The following is a description of a gene set: Human Gene Set: GOBP_CELL_JUNCTION_ORGANIZATION studied in species Homo sapiens A process that is carried out at the cellular level which results in the assembly, arrangement of constituent parts, or disassembly of a cell junction. A cell junction is a specialized region of connection between two cells or between a cell and the extracellular matrix., and this is the list of marker genes: CSK, DSP, TJP1, GDF2 (NCBI Gene Id 51423), NPAS4, DKK1, LNX1, FLRT2, PLXNB2, APLNR (NCBI Gene Id 187), ITGA3, WDPCP, TSC1, MYADM, CARMIL3, PKP2, GJB1, ITGB1, PIP5K1A, PSEN1 (presenilin 1), PCDHB14, PCDHB13, ADAM10, NRCAM, NRG3, C1QC, PTPRA, SNAI1, CAPRIN2, ABL1 (NCBI Gene Id 25), MIR431, PTEN, SEMA3F, CAV1, KIF5B, CDH22, ELMO1, CLDN6, UBE3B, KIRREL3, ACTG1, NECTIN3, LRRN1, RPS6, MYH10, PPFIA1, C1QL1, PCDHB10, CBLN4, NF1, MYCBP2, PTPRD, VCL, YWHAZ, SLC8A3, GABRG2, CDH2, APBB2, P2RX2, LRRC4B, CHD4, RAP2A, APOD, LRP4 (NCBI Gene Id 4038), DAPK3, FRMPD4, PERP, PPFIA4, SYN1, IL10, ITGA6, IL1RAPL1, DAG1, CNKSR2, VANGL2, CACNG2, NEGR1, PRKCA, GRM6, NGEF, CAST, CX3CL1, NFATC4, CLDN8, CDH6, PTK2B, LGMN (legumain), NTRK2, LHFPL4, DIP2A, TAOK2, GABRA4, NRP1, SEMA4D, SH3GL2, NFIA, LIMCH1, OPHN1, FZD5, HIPK1, VEGFA, FNTA, PTK2, IKBKB, CNTNAP2, CHRDL1, C5AR1, PTPRO, ALS2, SRF, BDNF, EPHA3, GABRA3, AGRN, FBXO45, SDF4, TBX5 (NCBI Gene Id 6910), CSMD2, CDH20, CBLN2, CD2AP, TANC1, OCEL1, CDH1, DRD1, ASIC1, GABRA6, RTN4, SLC30A1, CC2D1A, RAC3, ASIC2, SEZ6, GJB2, ZNF365, CACNA1S, CNTN6, COL4A5, RAPGEF2, DLG5 (discs large MAGUK scaffold protein 5), AGT, GABRA5, CDHR3, ROCK1, DAB2IP, SLC1A1, CLDN12, NTN1, GRID1, C1QB, ACTL8, PLXND1, LAMC1, RHOB, STRN, GAP43, RAB13, LRRTM3, CDH9, IQSEC1, CACNA2D2, CAMK2B, COL16A1, SLITRK5, ANAPC2, CRKL, ROBO2, WDR1, PFN1, PKN2, CHRNB1, MARVELD3, SRGAP2, BMP6, COL17A1, TUBB, ADD2, EFNB2, NPHP1, CDH19, TRPV4, ITGB1BP1, DHX36, PARD3, TLN1 (NCBI Gene Id 7094), ERBB4, BCAN, ZC4H2, NEDD4, NTRK3, HDAC6, DISC1, PHLDB2, SLC6A1, WHRN, EFNA1, GABRA2, MARVELD2, DAAM1, C3, CX3CR1, ZMYND8, DAB1, MEF2C, SNCB, GRHL1, ADGRB3, CNTNAP1, CLDN22, NAE1, POTEF, STRN4, ACE2, LRP8, PEAK1, GIT1, RIMS2, FAM107A, PTPRF, PPFIA3, DST, ELFN1, INSYN1, AFDN, LRFN1, POLDIP2, ZNF703, POTEJ, MECP2, NR1H4, LRFN2, LDB1, LRRC4, SLITRK2, CLDN3, FRRS1L, BCL2, SPARCL1, CLDN18, DLC1, L1CAM, APOE, LARGE1, BHLHA15, PDZD11, PCDHB4, CLASP1, TANC2, CTNNB1, CLDN17, SLC25A46 (solute carrier family 25 member 46), LMX1A, ITGA5, PCDH17, CNTN5, IL10RA, CLDN9, PAFAH1B1, BAIAP2, FRMPD2, LIMS2, TMEM108, INS, ARHGAP39, ITGA2, CNTN2, CACNB4, ABCC8, C1QL3, KIRREL1, SNCG (NCBI Gene Id 6623), SDK1, CDH10, ZDHHC12, CASKIN1, DOCK10, REST, CNTN4, SLITRK4, LRRK2, SRGAP2B, SEMA4C, IL1B, CBLN1, PGRMC1, GPBAR1, NEDD8, EPHA2, DIXDC1 (DIX domain containing 1), CAPZA1, GRID2, SHANK2, MYOT, CPNE6, MAPRE2 (NCBI Gene Id 51683), CHRNA1, EPHA4, NLGN2, AGO2, SDC4, PRNP, CCM2, S1PR2, CLSTN2, SPG11, TNC, ITPKA, LZTS1, PATJ, CDH15 (NCBI Gene Id 1013), MPP7, DVL1, LILRB2, CLDN14, CORO1C, GJC1, ADNP, CDH11, CRK, PRKACA, CLN3, ESAM, DOCK1, RAB39B, AFG3L2, CLDN15, LGI2, CLSTN1, LATS1, PALM, RAC1, TBCD, WASF3, MAP4K4, IL1RAP (interleukin 1 receptor accessory protein), PDCD6IP, GJA10, LIMS1, ARHGAP33, MTMR2, RAPGEF1, POF1B, CHRNB2, NEDD4L, ICAM5, WASL (NCBI Gene Id 8976), CDKL5, AJM1, ERC1, RAB29, PLXNC1, NECTIN1, PRICKLE1, CRMP1, PIK3R1, SLK, CLDN16, NTNG2, THBS1, CACNA2D3, CDC20, GJA5, PIN1, SNAI2, STAU1, SPECC1L, CAMKV, SEMA3E (NCBI Gene Id 9723), GHSR, PIP5K1C, RHOC, PLXNA1, FGF7, COL4A1, MACF1, SLC18A3, PLXNB3, CHRNA7, POU4F1, PCDHB16, CDH3, KCNJ8, KLK8, PCDHB2 (NCBI Gene Id 91503), SIGMAR1, ARMCX5-GPRASP2, PTPRS, DNAJA3, RER1, KDR, STON1, CD177, TRIM47 (NCBI Gene Id 91107), FERMT2, GPR158, CLDN10, NUMBL, DMPK, INSR, ZDHHC17, TGFB2, AMIGO2, CYFIP2, MRTFB, PTPN23 (NCBI Gene Id 96248), CLDN4, LRFN5, ACTB, DUSP22, WNT4, NPTN (neuroplastin), ADGRB1, NOS1AP, CAMK1, PCDH8, RAB8B, VPS35, IL1RAPL2, DSG3, HMCN2, NLGN4Y, ARHGAP12, FCGR2B, SPTBN2, NEFH, CRIPT, GRN, LAMA3, SPTBN4, SPOCK2, HTR4, ZDHHC2, RHOD, MESD, PKP3, CLDN24, CAP1, SPTB, LRIT3 (leucine rich repeat, Ig-like and transmembrane domains 3), NRN1, CSF1R (NCBI Gene Id 8156), SETD5, DSC1, SYNGAP1, CDH5, TJP3, FARP1, ACVRL1, PCDHGC3, DTNBP1, TEK, RAP1A, ARHGAP6, CFL1, MYOC, CTNNA1, ACTN1, PDZRN3, LAMTOR2, PDXP, F2R, CRB3, RHOA, PLEKHA7, RDX, AKT1, SLC39A9, TUBA1A, CUX2, DNER (NCBI Gene Id 92737), CLDN1, SHISA6, WNT7A, FLRT1, LIM2, ITGAM, NRXN1, TRIP6, EXT1, ITGB3, THBS2, UGT8, TENM4, PLXNB1, COLQ, NLGN3, SSH1, CDH24, THY1, MMP14, GRM5, PKHD1, TJP2, TMIGD1, GET1, CCDC39, SLITRK1, AMOT, LAMB2, RIMS1, MARK1, RAB17, RYK, SRGAP2C (NCBI Gene Id 653464), VMP1, CDH4, C1QA, ERC2, INAVA, BCR, CTTNBP2, ADGRL2, ARHGAP22, CTTN, SORT1, SRPX2, FYN, SYNDIG1, PRMT8, CTNNA2, CDH8, CDK5R1, NPHP4, GRIA1, SYN3, CAPRIN1, CBLN3, ARHGEF15, PPP1R9B, GABRA1, STK38, SIPA1L1, CLDN7, SRCIN1, ADD1 (adducin 1), DOCK4, GABRB3 (NCBI Gene Id 2562), HEG1, PARD6B, PLXNA4, FZD9, EFNA5 (ephrin A5), DOK7, CYFIP1, LRRTM2, ILDR1, WASF2, ANK3, LRFN4, NF2, HDAC7, PDLIM5 (PDZ and LIM domain 5), MYO9A, TNR, SORBS1, RAB3A, RELN, PAK3, PTK7, SLC9A1, SEZ6L, PFN2, FKRP, LRRC4C (leucine rich repeat containing 4C), TGFBR1, ABI3, PAK2, CLASP2, TLR2, HIP1R, RAP1B, RTN4R, NEFL (NCBI Gene Id 4747), HRG, DLGAP4, GPM6B, OXT, EEF2K, NLGN4X, NCKIPSD, IQSEC2, NRP2, PCDHGC5, PPFIA2, GPRASP3, SIX1, GJA4, GRIN2B, MIR142, F11R, SLITRK6, CDC42, ACTBL2, CAP2, PCLO, LZTS3, PECAM1, ERBB2 (NCBI Gene Id 2064), GRHL2, GPC4, VSIG10, MTSS1, GJA1, LINGO2, SH3BP1, GHRL (ghrelin and obestatin prepropeptide), MAPT, GJD3, CD9, NTRK1, DUSP3, NLGN1, NEURL1, FLRT3 (fibronectin leucine rich transmembrane protein 3), DBNL, GNPAT, GABRG3, LRTM2 (leucine rich repeats and transmembrane domains 2), CDH12, ADGRL3, MICALL2, SNCA, SLITRK3, FGFR1, SEMA4A (semaphorin 4A), EIF4G1, PKP4, PLXNA2, TESK2, PRKCH, TREM2, CDH17 (NCBI Gene Id 1015), GDNF (NCBI Gene Id 2668), NEUROD2, FSCN1, CDH7, ACHE, OGT, NRXN2, PCDHGC4, FGF22, DSG2, SNX27, ARHGEF9, APPL1, NTNG1, HAPLN4, FLOT1, PTPRJ, PLXNA3 (NCBI Gene Id 8276), PPM1F, EPB41L3, AMIGO1, ELFN2, SVEP1, FLCN, NPTX1, FER, ROCK2, PARD6A (par-6 family cell polarity regulator alpha), ARC, PTPN13, WASF1, GPM6A, CLDN34, ST8SIA2, DLGAP3, PLS3, CACNB2, EPB41L5, GSG1L, EGLN1, GNA13, BSN, KIFC3, FN1, CHCHD10, MIR105-1, NPHS1, GABRB2 (gamma-aminobutyric acid type A receptor subunit beta2), LIN7B, FBF1, LSR, DSG1, RAPSN, ARHGEF7, DNM3, ADGRF1, KIF2C, PRTN3, THSD1, PTPRK, CLDN19, DLG4, VCP, AJUBA, EPHB1, OCLN, IGSF11, WNT7B (NCBI Gene Id 7477), KY, SDK2, ACTN2 (NCBI Gene Id 88), ACTN3, LIN7C, AGAP1, CHMP2B, RCC2, WNT11, ABHD17B, ZDHHC8, TPBG, MPDZ, UBE2M, CORO2B, XIRP2, PICK1, ENAH, PCDHB3, PKP1, MAPK14, GLRB (glycine receptor beta), EZR, ZDHHC15, GREM1, SARM1, CDH18, EPHB3, EPHA7, PLPPR4, RPS6KA5, PCDHB6, ARL2, MUSK, CAMSAP3, CDH26, FZD1, SPARC, LRFN3, DCTN1, KPRP, FILIP1, LRRTM1, CLSTN3, SRC, CLDN5, PPFIBP2, POTEKP, JUP (NCBI Gene Id 3728), SHISA7, TNF, ABHD17A, MYLK3, ARF4, SIX4, IGF1R, ARHGAP44, CLDN20, TNS1, MYO1C (NCBI Gene Id 4641), APP, SHANK3, DLG1, IGSF9, RHOG, MAP1B, KCNK13, SYBU, GJB6, CDK5, DRP2, ITSN1, KIF1A, RAMP2, FGF13, SENP1, SLC8A2, CLDN11, PCDHB11, DSCAM, DBN1, LRRN3, PLEC, ZNF804A, LRRC24, IRX3, ABHD17C, RIMS3, TLN2, ADGRB2, DMTN (NCBI Gene Id 2039), CLDN23, IGSF21, LIN7A, GPHN, ARF1, SHANK1, AMIGO3, VLDLR, HOPX, WNT3A, GABRG1, SFRP1, PPFIBP1, TGFB3, C1QL2, MIR30B, ETV5, DRD2, CDH13, S100A10, MDGA1, WNT5A, F2RL1, SEZ6L2, POTEI, ABI2, SLC7A11, SNAPIN, NEDD9, ANK2, STAU2, VSTM5, SEMA7A, SLIT1, ACE, CTNND2, NUMB, SMAD7, ECT2, PUM2, PCDHB9, CXADR, PTPN1, SYN2, ARF6, CRTAC1, WHAMM (NCBI Gene Id 123720), HOMER1, ITGB4, PRRT1, GABRE, CLDN25, APC, JAM3, PCDHB5, SMAD3, TGFB1, IL17A, LAMA5, POTEE, CLDN2, PRKCI, LINGO4, INA, EPHB2, SLC12A5